The following is a description of a gene set: Human Gene Set: KEGG_MEDICUS_REFERENCE_GPI_ANCHOR_BIOSYNTHESIS species: Homo sapiens Pathway Definition from KEGG: PI+UDP-GlcNAc -- (PIGA+PIGC+PIGH+PIGP+PIGQ+PIGY+DPM2) >> PIGL >> PIGW >> (PIGM+PIGX) >> PIGV >> PIGN >> PIGB >> (PIGO+PIGF) >> (PIGG+PIGF) >> (GPAA1+PIGK+PIGS+PIGT+PIGU) >> PGAP1 >> PGAP5 -> G13046 GPI-anchor biosynthesis. Pathway ID: N00748. Pathway type: Reference. Pathway class: nt06018 GPI-anchor biosynthesis., and this is the list of marker genes: PIGU, PIGF, PIGB, PIGS, PIGW, PIGP (NCBI Gene Id 53821), PIGG, PIGH, PIGQ, PIGT, PIGV, PIGN, PIGL, PIGA (NCBI Gene Id 5277), PIGY, MPPE1, PIGM, PIGX, PIGC, PIGO, DPM2, PIGK, GPAA1, PGAP1